The following is a description of a gene set: Human Gene Set: GOBP_CELLULAR_RESPONSE_TO_HYDROPEROXIDE Any process that results in a change in state or activity of a cell (in terms of movement, secretion, enzyme production, gene expression, etc.) as a result of a hydroperoxide stimulus. Hydroperoxides are monosubstitution products of hydrogen peroxide, HOOH. studied in species Homo sapiens, and this is the list of marker genes: MGST1, DAPK1, CD36, SIN3A, TP53INP1, TMIGD1, OXR1, PRKD1, PRKCD